Given this list of marker genes KIF17, GRIA3, VILL, ACACA, OSBPL8, TRIM35, COQ8A, MEX3A, GUF1, KDM8, DDX39B, CTXN1, TMPRSS3, SLK, ACSL3, CCNA2, RWDD2A, MIF, GNAT2, TMEM106C, MESD, CREB3L2, MAPK14, NUDT2, AFF3, ZMYM4, SLC6A13, MCCC2, RNF113A, CDK2, NHSL2, LDHB, EXO1, ORC1, URI1, CFAP68, TRIM47, RRP1B, HDLBP, CLDN12, HMOX2, IL11RA, KLHDC10, GLOD4 (glyoxalase domain containing 4), PHKA1, RBBP5, PTPRE, PHKA2, DYNC2I2, HMMR, TGM2, NSUN2, TMEM158, MYOF, DPF2, CMPK2, HK1, HTRA2, MACROH2A2, IDI1, PLK1, ZNF608, SLC22A16, CCDC86, SPI1, LRRC66, DGKG, SLCO3A1, CAD, RSRC1, WDR75, HROB, BPGM, PEX5, ATP13A2, FADS1, ATG4C, FAM229B, SUCLG2, RAPGEF5, EPRS1, MCTP1, FANCB, AURKA, CUL7, SOX12, NFAM1, PAICS, LTBR (lymphotoxin beta receptor), HRG, FRRS1, INTS1, MTCL2, MATN2, NUDCD2, PTDSS2, NUPR1, BRCA1, KANSL1L, PIGY, COPS5, MCM5, CUL9, GTF2E2, COQ6, ALAS1, FDPS, PLXNB2, RUVBL2, GMDS, SRSF7, HNRNPA1, AK1, PRDX4, VSX2, NUFIP1, PPA2, ACADM, FLYWCH2, DNAJB4, RLIG1, MAT1A, EIF2D, EIF4B, NXF2, TMT1A, KYAT3, ERP29, POLE2, CAMK1, CHERP, COL16A1, HOXA5, PWWP2B, TNS2, IFT172, LDLRAD3, CDCA2, MAOA, CEP83-DT, UNC93B1, FOXP3, SOX6, DCAF8, GABRR1, NHP2, LXN, TREML2, MZT2B, PDXP, CPSF2, TLX2, NUP155, BRI3, BDH2, SLC45A4, SLC25A13, TEX2, MLKL, MSRA, TGFA, COPS4, NUDC, INAFM1, MTFR1, TRIQK, NOB1, TDRD3, PNP, TPD52 (tumor protein D52), CAPG, TUFT1, FMO2, RTL8C (NCBI Gene Id 8933), NPHP1, IARS1, ZFAND5, GRWD1, KCTD12, FAM217B, RAMP1, GATB (glutamyl-tRNA amidotransferase subunit B), HSD17B12, DDX19A, TNNI3, NDUFAF2, ELOVL6, CC2D2A, ADAM9, KIAA1958, TOPORS, GSE1, ABCD3, CHML, FBXO3, MYLK, RSL24D1, SYPL1, NBN, RNF150, here is a description of the gene set: studied in species Homo sapiens from publication Konuma T, Nakamura S, Miyagi S, Negishi M, Chiba T, Oguro H, Yuan J, Mochizuki-Kashio M, Ichikawa H, Miyoshi H, Vidal M, Iwama A (PMID 21540074) Human Gene Set: GSE27786_LSK_VS_NKTCELL_UP Genes up-regulated in comparison of LSK versus NKT cells. Each fraction of mouse hematopoietic cells was purified by cell sorting from bone marrow of 8-week-old C57BL/6 mice, and its gene expression was analyzed.